Given this list of marker genes OFD1, MST1, GPIHBP1, SLC7A7, MT-TQ, BRCA2, HMGCL, PALLD, INSR, APPL1, UQCRH, PRIM1, TLR4, SCNN1B, KLF11, NSMCE2, STUB1, PAX4, SLC26A9, SPINK1, FLI1, CCDC47, ESAM, DIS3L2, UBR1, MMUT, ASL, ERAP1, MPV17, PALB2, CTRC, CYBC1, CDKN2A, CDKN2B (cyclin dependent kinase inhibitor 2B), HMOX1, MT-ND6, CEACAM3 (CEA cell adhesion molecule 3), JAG1, CFTR, GLUD1, PNPLA2, SMAD4, HNF1A, XPNPEP3, IL12A, MEFV, STAT3, SLC9A3, GPR35, CDC73, GNA11, MT-CO3, CCR1, CBS, MT-TL1, MT-CO2, GPC3, C4A, BCKDHA, CAV1, ACTG2, APOC2, SLC25A13, PRTN3, BSCL2, GNAS, HAMP, IVD, KCNJ11, KLRC4, SERPINA1, CNOT1, DNAJC21, TRMT5, GCLC, FOCAD, CASR, GK, CTLA4, YARS1, GCGR, MT-TS2, PRSS2, MT-TW, PTF1A, NEUROD1, EFL1, INS, ATP8B1, HNF1B, MIF, STX1A, PDX1, MT-ND4, MT-ND1, CPA1, HLA-B, EIF2AK3, CLCA4, G6PC1, MADD (MAP kinase activating death domain), GPC4, CTNS, GCK, BRCA1, MT-TH, LPL, SBDS, MT-TF, CDKN2C, NADK2, BLK, DCTN4, CIDEC, ABCC8 (ATP binding cassette subfamily C member 8), SRP54, HNF4A, TP53, FAS, PCCB, COX4I2, RABL3, EDNRA, FAH, NSD2, CEACAM6, SEMA4D, KCNN4, LMNA, NDUFS3, PDE11A, VHL, LMF1, SCNN1A, GATA6, AP2S1, IL23R, PUF60, MT-CO1, MT-ND5, AGPAT2, UCP2, MAFA, IFT172, IKZF1, NFS1, TKFC, AIRE, IL12A-AS1, CDKN1B, ATP6AP1, SLC37A4 (solute carrier family 37 member 4), PTRH2, STAT4, TRPV6, IL10, PTPN22, CDKN1A, ATP7B, IFNGR1, HJV, PPARG, TGFB1, LBR, CRELD1, SLC16A1, ABCB4, PRSS1, FCGR2A, TCF4, MEN1, KRAS, HLA-DPA1, CEL, HFE, SLC6A14 (solute carrier family 6 member 14), SMARCAL1, CCND1, YY1, UBAC2, RNU7-1, SLC11A1, PCCA, ALMS1, HLA-DPB1, GSTM3, ARX, APOE, here is a description of the gene set: Abnormality of pancreas physiology An anomaly of the function of the pancreas. Human Gene Set: HP_ABNORMALITY_OF_PANCREAS_PHYSIOLOGY species: Homo sapiens